The following is a description of a gene set: Any process that modulates the frequency, rate or extent of auditory hair cell differentiation. Human Gene Set: GOBP_REGULATION_OF_INNER_EAR_AUDITORY_RECEPTOR_CELL_DIFFERENTIATION studied in species Homo sapiens, and this is the list of marker genes: DLL1, FGF2, HES5, ESRP1, NOTCH1, HES1, MYCL, MYCN, ATOH1, HEY2